The following is a description of a gene set: Genes predicted to be targets of miRBase v22 microRNA mmu_miR_344f_3p in miRDB v6.0 with MirTarget v4 prediction scores > 80 (high confidence targets). studied in species Mus musculus from publication Chen Y, Wang X (PMID 31504780) Mouse Gene Set: MIR_344F_3P, and this is the list of marker genes: Vamp4, Ric8b, Haghl, Sort1, Sema4a (NCBI Gene Id 99554), Ldhc, Gabrb2, Gm973, Smim14, Elac1, Stxbp4, Pak2, Reep5, Slc12a6, Amz1, Gabra4 (gamma-aminobutyric acid type A receptor subunit alpha 4), Irag1, Cggbp1, Ifit3, Rnps1, Rab5a (NCBI Gene Id 66987), Kif21a, Fbxw26, Mbtps2, Tifa, Znrf3, Lce6a (NCBI Gene Id 78382), Ankrd61, Sulf1, Map2, Klhl13, Chmp4c, Lgalsl, Hnrnpa2b1, Wtap, Ptpn9, Il1rn, Mitf